Given this list of marker genes NAGS, ESCO2, NAT8, NAT8B, EP300, KAT2B, ATAT1, NAT8L, here is a description of the gene set: Human Gene Set: GOMF_L_AMINO_ACID_N_ACETYLTRANSFERASE_ACTIVITY studied in species Homo sapiens Catalysis of the reaction: acetyl-CoA + a L-amino acid = CoA + an N-acetyl-L-amino-acid. In some cases acetyl phosphate can be used as a donor.